Given this list of marker genes Bace2, Ago2, Aatf, Itm2c, Itm2a, Abca7, Itm2b, here is a description of the gene set: Any process that stops, prevents, or reduces the frequency, rate or extent of the chemical reactions and pathways resulting in the formation of amyloid precursor protein (APP), the precursor of amyloid-beta. studied in species Mus musculus Mouse Gene Set: GOBP_NEGATIVE_REGULATION_OF_AMYLOID_PRECURSOR_PROTEIN_BIOSYNTHETIC_PROCESS